The following is a description of a gene set: Human Gene Set: NAKAMURA_ADIPOGENESIS_LATE_UP from publication Nakamura T, Shiojima S, Hirai Y, Iwama T, Tsuruzoe N, Hirasawa A, Katsuma S, Tsujimoto G (PMID 12646203) studied in species Homo sapiens Genes up-regulated in mesenchymal stem cells during late phase of adipogenesis, defined as days 7 to 14 of culturing with adipogenic hormones. Human bone marrow mesenchymal stem cells (hMSCs) give rise to adipocytes in response to adipogenic hormones. An in-house cDNA microarray representing genes was employed to characterize the modulation of genes involved in this process. A total of genes showed temporal gene expression changes during adipogenesis, including genes encoding transcriptional regulators and signaling molecules. Semi-quantitative RT-PCR analyses confirmed differential expression at the transcriptional level of several genes identified by cDNA microarray screening. Cluster analysis of the genes regulated during the late phase (from day 7 to day 14) of hMSC adipogenesis indicated that these changes are well correlated with data previously reported for murine preadipocytes. However, during the early phase (day 1-day 5), the modulations of genes differed from those reported for the preadipocytes. These data provide novel information on the molecular mechanisms required for lineage commitment and maturation accompanying adipogenesis of hMSC., and this is the list of marker genes: STAT5B, TPR, CDH13, PHKG1, SERPINB9, STOM, ZNF24, PDE10A, IL22RA1, PUS7L, HACD3, AKAP10, SUMO1, FASN, IRS2, P3H2, MMD, HMGCS1, GM2A, ACSL5, EFNA1 (NCBI Gene Id 1942), GCC2, GLT8D2, CHCHD3, PPP1CC, GAS6, S1PR3, FOXO1, ABCA1, IGF2R, CYBRD1 (NCBI Gene Id 79901), EFTUD2, LIPE, SMARCD2, ACVR2A, RAB31, MAPK1, MAPK6, PPARG, TNFRSF21 (TNF receptor superfamily member 21), IGF2, CIDECP1, PLIN2, SMPD1, TMEM119, NID1, STX3, CKS2, XYLT1, RAB5A, USP4, MYADM, TGFBR3, IRF9, CD36, ACSF2, ACACB, MRPS6, ACACA, PLK3, FABP4, MGMT, NOVA1, MGP, NPTXR, MYB (NCBI Gene Id 4602), YAE1, G0S2, INSIG1, TGFB2, LPIN1, OXR1, CDKN2C, NFIL3, PRKAR2B, CEBPD, CCDC50, MYC, TGFB1, ABL1, ATF3, SIK2, SMIM3, PRSS23-AS1, BLOC1S1, E2F4, COL11A1, SCD, CTNNB1, ELK3, SLC27A4, CCRL2, COL6A3, CCNG1, PPP2R5A, FAM174C, PPP1CA, PTPRA